Given this list of marker genes RANBP1, CHEK1, UBXN2B, CEP85, MAP9, NEK2, NSFL1C, KIF11, KIF25, here is a description of the gene set: Human Gene Set: GOBP_REGULATION_OF_MITOTIC_CENTROSOME_SEPARATION Any process that modulates the frequency, rate or extent of the separation of duplicated centrosome components at the beginning of mitosis. species: Homo sapiens